Given this list of marker genes IL18RAP, MFSD9, LGALS1, RUNX3, ELL2, PPP3CC, TAFA2 (TAFA chemokine like family member 2), CNNM4, GUCA2A, STOM, LINC03032, CDADC1, ZSWIM6, SLC2A3, CFHR2, PLEKHB2, CCL5, NAGS, CRAT, CEP89, SLC39A11, CCDC107, TP53BP1, PCDHGA10, SOWAHC, ABCG5, BLTP3B, IL4I1, LIMS1, CENPJ, TGFBI (transforming growth factor beta induced), BCL2L1, LINC00626, GPR137B, AGR2, TMX1, SLCO4A1, SLBP, FRMD4B, RPPH1, NMNAT3, GRB2, SRRT, FBXW7, PMEPA1, TMEM62, EOMES, ECE1, TSPAN15, NDUFA6, PIK3R1, KCNK12, SLC8A1-AS1, LYVE1, HYLS1, DDX19B, EPS8, IGSF9B, CYTH2 (NCBI Gene Id 9266), PRKAB1, TBC1D8, DTL, PCDHAC2, CSPG5, HDLBP (high density lipoprotein binding protein), ENSG00000254531, TUBA3D, GCNT1, ANTXR2, RTN4, SPPL2A, WSB2, CCNE2, PMM2, POLR2F, PIGT, HIVEP3, SYT11, CENPU, FBXO7, PDZD4, GNS, PAM, ATP2B1, KIF21A, TMEM216, APOBEC3C, MTRR, CTSH, CD109, AFG3L1P, FEZ2, NASP, PARP8 (poly(ADP-ribose) polymerase family member 8), SPRED2, ANKRD30BP3, CD34, N4BP3, SRI, TFAP2E, SURF2, TP53INP2, PAPSS1, SUSD1 (NCBI Gene Id 64420), SMIM31, DGCR8, MAPKAPK2, CHN1, BIN3, PRLR, ELF4, FAM3D, ONECUT3, ANXA2P2, KCNN4, SLC6A1, CLPTM1, DOK3, GLTP, RAPGEF1, PFKFB3, NCOA6, PITPNA, IGFBP4, ECPAS, OR2C3, F2R (NCBI Gene Id 2149), DHRS7B, TNFRSF12A, AMPD3, BARD1, PTPN13, LMNA, SAP30L-AS1, MCAM, ANXA2, S100A10, TAF1B, FLT1, CDS2, TMED9, DPYSL2, SAMD3, PTTG3P, CLIC3, TSC22D3, NEU1, CMTM3, NAT8, HELLS, TNF, MGAT2, MCOLN2, FAIM2, ST7, PRDM1, CRHR1, ODC1, FLRT2, ZNF90 (NCBI Gene Id 7643), KLHDC10, CYRIB, MRC2, VN1R3, ADRB2, RABGAP1L, RECQL, PAK4, KEAP1, ATP2A2, DSE, CTSZ, LGALS2 (galectin 2), SRP72, PKP1, TKTL1, NDUFA11, MT2A, DEFT1P, DPY19L1, SNTB2, RAC1, SCGN, KNL1, SAT1, RTL6, TNFRSF1B, RABAC1, ELL, NECTIN3, KCTD1, NEK4, CENPE, SNRNP200, TXN, PBX3-DT, here is a description of the gene set: from publication Chevalier N, Jarrossay D, Ho E, Avery DT, Ma CS, Yu D, Sallusto F, Tangye SG, Mackay CR (PMID 21471443) studied in species Homo sapiens Genes down-regulated in comparison of naive CD4 T cells versus CD4 effector memory T cells. Human Gene Set: GSE26928_NAIVE_VS_EFF_MEMORY_CD4_TCELL_DN